Given this list of marker genes IGF1R, ZEB2 (NCBI Gene Id 9839), SHH, GPRASP2, KMT2D, SCN1A, FOXC1 (forkhead box C1), POU1F1, GJA5, FREM2, MAD2L2, SLC25A19, GPR143, CDC42BPB, NDE1, JMJD1C, CEP290, BCOR, SMO, HPS6, ALX4, PPP1CB, PRPS1, HIRA (histone cell cycle regulator, NCBI Gene Id 7290), RPGRIP1, WNT3 (Wnt family member 3), CAPN15, GRIP1, GDF3, TP63, ALX3, B4GAT1, PDE6C, NEU1, ASNS, IKBKG, JARID2, DLX6, H19, VSX1, FKBP6, NUAK2, STIM1, SMOC1, PTPN23, MED25, B9D1, HPS5, ZNF408, MAB21L1, PEX7, ALDH1A3, NOTCH1, SMC5, KIF1B, LMX1B, LHX3, FANCE, AP2M1, CACNA1F, DLL4, STAG2, GDF6, AP3D1, ARSL, B3GALNT2, SON, PLK4, OTX2, PAX2, MPDZ, KDM6A, WNT10B, ELOVL4, HHAT, EIF4H, KNSTRN, COX7B, HRAS, PPP2R1A, TYR, PLXNA1, BUB1, SEMA3E, FGFRL1, ANKRD11, TUBA1A, ERCC3, CTDP1, FIG4, FOXA2, SLC6A1, ZNF699, MAX, RPGRIP1L (RPGRIP1 like), BMP4, SPECC1L, ERCC6, ERCC5, NR4A2, SDHC, GNPAT, CTBP1, BDNF, FOXC2 (NCBI Gene Id 50824), VAX1, EPS15L1, GLYCTK, HPS4, CPLX1, WDR11, SETD2, PQBP1, POLR1B, LDHD, ALX1, RAX, DNAJC30, DOCK6 (NCBI Gene Id 57572), KERA, RAB3GAP1, PIK3CD, EXOC2, PROM1, SIN3A, TBX4, ADAMTS10, GP1BB, GJA1, SNF8, HMX1, SEM1, CTNNB1, DLST, PRSS56, NFIX (NCBI Gene Id 4784), RNU4-2, RNF113A, SYNGAP1, DAG1, ROBO1, CEP120, EBP, SPOP (NCBI Gene Id 8405), YME1L1, TBL1XR1, SRD5A3, CASK (NCBI Gene Id 8573), FREM1, SEC24C, FOXL2, LIMK1, AASS, TRIT1, ACTB, SETD5, LIG4, FBXW4, SNAP29, CFAP418, PROP1, VPS37D, PITX2, MITF, PRPH2, ERCC4, TUBA8, FANCM, DLX5, INTU, OTUD5, DKC1, TRIM28, SMCHD1, DDHD2, BUD23, DACT1, PUF60, HNRNPU, FANCA, NRAS (NRAS proto-oncogene, GTPase), ZFX, GLI2, POLR1C, RPGR, MAP2K2, TBX15, KRAS, KIF21A, LHX4, COL4A1, RRAGC, HS2ST1, PIK3CA, WT1, B9D2, EIF4A2, FANCG (NCBI Gene Id 82603), MACF1 (microtubule actin crosslinking factor 1), BEST1, SMAD4, COL25A1, TSPAN12, ADAMTSL1, COX14, ATF6, GABBR1, RFC2, MAF, BUB1B, UGP2, TMEM107, ERCC1, SYCE1, DNMT3A, TCTN2, WNT7B, RTTN, SLC25A11, HCCS, CHUK, SOX10, NEXMIF, TUBGCP4, DNA2, PROKR2, TENM3, CHD6, PDE6D, POMT2, FBXW11, HYLS1, LETM1, FANCD2, POMGNT1, GTF2IRD2, TCTN3, CPAMD8, CDON, GNAT2, PDE6H, SLX4, DCT, KIF11, IFT74, NF1, DIS3L2, GPC3, PTCH1, CEP57 (centrosomal protein 57), PXDN, FGFR1, FANCI, ERCC8, ELN, ITPR1, HSPG2, RAB3GAP2, GTF2E2 (NCBI Gene Id 2961), RREB1, PHGDH, ATAD3A, GRIA4, FANCC, ABCA4, FAM111A, VHL, TMEM127, UBE2T, SDHB, ABCB6, MTSS2, PRR12, RSPO2, VAC14, CACNA1C (NCBI Gene Id 775), SLC2A1, SLC38A8, ERCC2, GATAD2B, CRPPA, GTF2IRD1, MKS1, VPS35L (NCBI Gene Id 57020), GTF2I, RET, FANCB, SIX6, PIK3R1, TUBB3, VPS13B, GTF2H5, RFX7, CLIP2, MAPRE2 (NCBI Gene Id 51683), HDAC6, DOCK7, MED12, TRIM44, FKRP, SLC45A2, DONSON, PAX3, JAM3, COMT, RNF135, MBTPS2, SOX3, BTRC, POMGNT2 (protein O-linked mannose N-acetylglucosaminyltransferase 2 (beta 1,4-)), ERF, RERE, UFD1, SNX10, COL18A1, SDHAF2, ZIC1, CENPF, NR2F1, POMT1, MIR184, HMBS, RIPK4, OSGEP, CHD7, METTL27, PALB2, MED13L, COL2A1, CHD2, BUB3, TMTC3, EOGT, PIGN, STX1A, ATOH7, POLR3A, TONSL, MEF2C, PCYT1A, STRA6, TMEM67, C12orf57, RMRP, TUBB, CSPP1, PAX6, TCOF1, ELP4, TBR1, XRCC2, PRIM1, CNGA3, FOXE3, ALDH6A1, TUBB2B (NCBI Gene Id 347733), NSD2, TBC1D20, YAP1, LYST, MC1R, BRCA2 (BRCA2 DNA repair associated), MDH2, CEP85L, TBL2, MPLKIP, BRCA1, TMEM231, PORCN, LMBRD2 (NCBI Gene Id 92255), SLC24A5, ARMC9, SDHA, FZD4, FANCL, KCNK4, RBBP8, TBX1, TXNDC15, OCA2, NCF1, MFRP, PDGFRB, REST (RE1 silencing transcription factor), POGZ, LRP2, FRAS1, LRP5, TRIP13, LARGE1, RECQL4, LAMB2 (NCBI Gene Id 3913), GJA8, CARS1, SIX3, KIF14, ESCO2, GPR161, APC, BAZ1B, GMPPB, POMK, DPYD, ADAMTS17, NSUN2, ACTG1, NDUFB11, DHCR7, TMEM237, TFAP2A, NDP, TOMM7, SALL1, BLOC1S3, TBCE, ARVCF, CC2D2A, SLC25A24, PITX3, LTBP2, RHOA, FZD5, MYRF (NCBI Gene Id 84755), ASPH, TUBGCP6, KIF7, ALDH1A2, RXYLT1, RAD51, ARX, NHS, ARHGAP31, POU6F2, NUP188, CNGB3, XYLT2, EPG5, HESX1, FBN1, SOX2, TMEM216, ZSWIM6, ATN1, RBP4 (retinol binding protein 4), RAB18, SMG9, HMGB3, WDR37 (WD repeat domain 37), RBPJ, MAB21L2, KIF15, TOGARAM1, TMEM270, RAD51C, INTS1, SF3B2, NAA10, VSX2, SDHD, GLI3, MYO5A, HNRNPK, MAFB, FKTN, SCN8A, POLR1D, RARB, FGF3, BLOC1S5, WDR73, OCRL, MT-CYB, ZPR1, PTF1A, CRYAA, RFWD3, SALL4, TKFC, FANCF, TARS1, NEFL, FH, RB1, PHOX2A, PHYH, ARNT2, FDFT1, CHN1, CRB1 (NCBI Gene Id 6107), BRIP1, TMEM98, PIEZO2, AARS1, TCTN1, here is a description of the gene set: species: Homo sapiens Aplasia/Hypoplasia affecting the eye Human Gene Set: HP_APLASIA_HYPOPLASIA_AFFECTING_THE_EYE